The following is a description of a gene set: Human Gene Set: HP_ABSENT_DISTAL_INTERPHALANGEAL_CREASES Absent distal interphalangeal creases Absence of the distal interphalangeal flexion creases of the fingers. studied in species Homo sapiens, and this is the list of marker genes: IHH, TPM2, ADAMTS15, HOXD13, RBBP8, TLK2, LMX1B